Given this list of marker genes Cad, Ptprv, Cald1, Higd1a, Tmem255a, Pidd1, Arap2, Nav1, Tbx3, 2500002B13Rik, Serpine2, Fat1 (NCBI Gene Id 76752), Snai1, Cdkn1a, Myc, Sem1, Tpd52l1, Sall4, Mab21l3, Epb41l4aos, Pakap, Trp53inp1, Abhd11os (abhydrolase domain containing 11, opposite strand), Pfkp, Eng, Slc19a2, Ccnd2, Egln3, Ndufb6, Cdk6, Zfp365, Pgm1, Map3k20, Bhlhe40, Cthrc1, Bloc1s2, Slc16a3, Ift20, Itga9, Ephx2, Pierce1, Exoc4, Nomo1, Dnai1, Ggta1, Rps19 (NCBI Gene Id 20085), Lin28a, Ggct, Pfkl, Ptk7, Cdc34b, Mix23, Nme4, Cpne2, Aen, Aldoa, Pros1, Pgk1, Hk2, Gtse1, Arrdc3, Ldha, Rpl36, Krt19, Garin5b, Eif2s3y, Zmat3, Ddx3y, Ei24, Dcxr, Peg3, Adm, Prelid2 (NCBI Gene Id 77619), Ptp4a3, Snrpf, Timm17a, Synm, ENSMUSG00000127189, Gm42047, Dynlt2a1, Fam162a, Ddit4l, Sf3b5, Trim6, Id1, Trim71, Gpc3, Foxo3, Srrm2, Dapk1 (NCBI Gene Id 76556), Gm3095, Bax, Igf2r (NCBI Gene Id 16004), Plk2, Ak1, Lypd1, Lnpep, Piezo1, Pmaip1, Pfdn2, Slc66a3 (NCBI Gene Id 97797), Gm15987, Dusp5, Bhlhe41, Eif4ebp1, Pla2g12a, Kifc1, Marchf5, Hspa1b, ENSMUSG00000122396, Cpt1c, Ccnd1, Rpgrip1, Rpl27a, Bnip3, Fam181b, Ercc5, Plxdc2, Ddit4, Slc2a1, Sesn2, Fgf15, Ero1a, Igdcc4, Prtg, Cep170b, Egln1, Tpi1, Slc39a7, 2410006H16Rik, Gria3, Galk1, Phlda3, Meg3, Def6, 1500009L16Rik, P4ha1, Gas5, Vcan, Vegfa, Polr2k, P3h2, Eda2r, Eno1, Nr6a1, Tap1, Grhpr, Ak4, Lpp, Cep15, Cpped1, Ankrd37, Psrc1, Mapkapk3, Fbn2, Rnf126, Lrrfip1 (NCBI Gene Id 98585), Cox6b2, Ccng1, Ckap2, Rbm38, Nkx6-2, Mt1, Rnf169, Wnt3a, Cd81, Actn1, Ptpn14, S100a10, Gpi1, Ddias, Perp, Foxb1, Fst (NCBI Gene Id 99160), Bex1, Fbxw9 (NCBI Gene Id 68628), Soat1, Slc2a3, Snora74a, Agpat5, Klhl26, Mt2, Foxl2, Zfp688, Ctse, Itga8, Ano3, here is a description of the gene set: The p53 tumour suppressor functions as a transcriptional activator, and several p53-inducible genes that play a critical proapoptotic role have been described. Moreover, p53 regulates the expression of various proteins participating in autoregulatory feedback loops, including proteins that negatively control p53 stability (Mdm2 and Pirh2) or modulate stress-induced phosphorylation of p53 on Ser-46 (p53DINP1 or Wip1), a key event for p53-induced apoptosis. Here, we describe a new systematic analysis of p53 targets using oligonucleotide chips, and report the identification of dapk1 as a novel p53 target. We demonstrate that dapk1 mRNA levels increase in a p53-dependent manner in various cellular settings. Both human and mouse dapk1 genomic loci contain DNA sequences that bind p53 in vitro and in vivo. Since dapk1 encodes a serine/threonine kinase previously shown to suppress oncogene-induced transformation by activating a p19ARF/p53-dependent apoptotic checkpoint, our results suggest that Dapk1 participates in a new positive feedback loop controlling p53 activation and apoptosis. from publication Martoriati A, Doumont G, Alcalay M, Bellefroid E, Pelicci PG, Marine JC (PMID 15608685) Genes up-regulated in apoptotic tissues (neuroepithelium) after MDM4 knockout. studied in species Mus musculus Mouse Gene Set: MARTORIATI_MDM4_TARGETS_NEUROEPITHELIUM_UP